Given this list of marker genes RPTOR, MIR126, PPARG, MIR29B1, ALDH1A2, FRS2, LAMB1, STXBP4, FLT1, MIR149 (NCBI Gene Id 406941), PRL, HPN, GPC3, RAB33B, EYA1, PDCL3, TNMD, EGR3, DEAF1, HSF1, B4GALT1, MIR499A, IFT80, ARNT, WNT2, MIR10B, APOE, PTN, MIR129-1, MED1, IFT52, AKT3, IL10, VEGFB, NLRC3, HMOX1, MIR22, STAT1, CDKN2A, ITGB3BP, NKX2-3, MIR10A, FZD7, EXTL3, FGF1, SNAI2, PTCH1, STK3, GATA3, RTN4, HAS2, PDCD10, SERPINB5, GPR15LG (G protein-coupled receptor 15 ligand), ANG, HLX, FGF10, CDC42, SULF1 (NCBI Gene Id 23213), SIRT6, LRG1, PROX1, NRP1, CASK, SP1, EFNB2, STK11, NR1D1, XBP1, NKX2-8, MIR24-1, MIR23A, MIR483, EGF, TGFB1, EPGN, BMPR1A, LACRT, NF1, WDR48, REG3A, SERPINF1, PAX2, BAX, HMGB1, RICTOR, KDM5B, ODAM, TGFA, HMGA2, ERBB3, MEF2C, DAB2, IFT172, CAV2, ZNF304, FA2H, NOTCH2, LIMS2, JAG1, SOX11, APLNR, KRIT1, ZEB1, EDNRB, PTPRN, CCL11, MIR152, SEMA5A, SYNJ2BP, IRF6, MIR146A, MIR20B, HIF1A, YAP1, WNT10B, MIR27A, GPBAR1, KDF1, SFRP1, COL4A3, GDF2, TNF, PYGO2, TGM1, ATP5IF1, AREG, IRS2 (insulin receptor substrate 2), FGFBP1, SPARC, MIR30B, PHOX2B, MIR15A, IFT57, MIR132, CDH3, FUT1, MAP2K5, GDF5, JAML, CTNNB1, MIRLET7B, ESRP2, PPP1R16B, NRP2, AQP11, ST8SIA1, FGF2, ENG, WDR77, CFLAR, PHB2, MIR361, KRT4, VASH1, KDR, FLT4, MIR15B, MYCN, WNT5A, ITGA4 (integrin subunit alpha 4), PTPRK, CCND1, LEP, LAMC1, HMGN1, MIR193A, EGFR, TP63, LIMS1, MIR200C, FGF16, SULF2, AGGF1, NUPR1, FMC1, PRKCA, APOH, ERRFI1, VEGFC, CXCR3, IHH (NCBI Gene Id 50819), BID, MIR16-1, DLG1, MAGED1, TNFAIP3, MIR494, EMC10, RBPJ, CCL26, MIR98, SHH, MIR101-1, VDR, HTR2B, TIE1, DLL4, ITGB3, STAT5A, MTSS1, MIR150, TCF7L2, PDCD6, NRARP, CDKN1B, MIR222, NKX2-6, ARX (NCBI Gene Id 619216), CD109, NEAT1, WDR13, PRKD1, HSPG2, DLX5, GHRL, MYDGF, CYBA, ANGPT1, HOXA5, MIR503, CDC73, KLF9, ZNF703, ROBO1, A4GNT, TMIGD1, EPB41L4B, CCR3, PIK3CD, MIR125B1, MIR92A1, HES1, REG3G, ISL1, AKT1, SAAL1, STAT3, TRIM24, BRCA2, TBX1, RUNX2, IL26 (interleukin 26), CXCL12, SOX9, MIR495, GRN, TNFSF12, CCL5, MYC (MYC proto-oncogene, bHLH transcription factor), PDX1, NKX3-1, GPX1 (NCBI Gene Id 2876), BCL11B, TACSTD2, CEACAM1, NKX2-5, STK4, B2M, UHRF1, MIR205, MIR30E, MIR2355, THBS4, ATOH8, IL12A, CYP7B1, ERBB2, MIR497, CRNN, EPPK1, FGFR1, HDAC6, SFN, JUN, SMO, WNT3A, BTK, PDPK1, NUS1, CCL2, SMAD3, MIR130A, IGF2, MTA3, CDK6, JCAD, MIR424, HMX2, POLD4, FUT2, VEGFA, CDKN2B (NCBI Gene Id 1030), LAMA5, VASH2, CDKN1C, MIR329-1, NME2, MIR410, BMP6, ACVRL1, OSR2, NGFR, FOXP2, NODAL (nodal growth differentiation factor), SLC39A9, NOD2, GLI1, MCC, GHSR, MMRN2, MIR492, SLURP1, THBS1, RGCC, TGFB2, C5AR1, NOTCH1, FGF18, NME1, SIX4, ATP5F1A, ADAM17, DRD2, OVOL2, INTU, NR4A3, RAP1GAP, MIR29C, PDGFB, HRAS, RUNX3, CDK4, NFIB, PROK1, DSC1, EREG (NCBI Gene Id 2069), APELA, HMGB2, AGTR1, FOXE3, ERBB4, PRKDC, ZFP36, FGFR2, PKHD1, F3, PTPRM, SCN5A, EGFL7, SAV1, BMP4, PLXNB3, SRSF6, PPARD, RB1, FGF7, OVOL1, BMP5, TINF2, MARVELD3, PEX2, GATA2, SCG2, SGPP2, MIR21 (microRNA 21), CNMD, ECM1, CDH13, WNT7A, ZFP36L1, PAX6, MIR29A, DLX6, TGFBR1, SIRT1, FLCN, GATA6, MDK, RREB1, IQGAP3, HES5, MIR342, TGFBR3, FBXW7, NOG, MIR133B, TEK, NR4A1, SCAND3, IGF1, IFT74, AR, AIMP1, IL12B, MIR34A, PRKD2, CAV1, PLCG1, SFRP2, EAF2, MIR487B (NCBI Gene Id 664616), ZNF580, OSR1, MIR135B, FGF9, MIR181C, MIR27B, NRAS, DUSP10, CLDN1, TACR1, ALOX5, BAD, SIX1, CCL24, NR2F2, DAB2IP, PGR, APLN, MIR26A1, DBH, MMP12, here is a description of the gene set: Any process that modulates the frequency, rate or extent of epithelial cell proliferation. Human Gene Set: GOBP_REGULATION_OF_EPITHELIAL_CELL_PROLIFERATION studied in species Homo sapiens